Given this list of marker genes Gli2, Lrp5, Gli1, Bmpr1a, Opn4, Flt1, Ninj1, Slc17a6, Opn5, Th, Wnt7b, Smad5, Slc6a3, Spi1 (Spi-1 proto-oncogene), Cd248, Smad9, Lef1, Amh, Drd2, here is a description of the gene set: The developmental process in which an anatomical structure is destroyed as a part of its normal progression. species: Mus musculus Mouse Gene Set: GOBP_ANATOMICAL_STRUCTURE_REGRESSION